Given this list of marker genes Aoc3, F8, Gstp1, Ednrb, Il4, Pik3cg, Tnf, Plscr1, Ptgs2, Nlrp6, Itih4 (NCBI Gene Id 16427), Alox5ap (arachidonate 5-lipoxygenase activating protein), Adora1, Ffar2, Pla2g2d (NCBI Gene Id 18782), Park7 (NCBI Gene Id 57320), Dnase1l3, Tnfsf11, Ugt1a1, C2cd4b, Rhbdd3, Prcp, Icam1, Reg3g, Saa3 (NCBI Gene Id 20210), Eif2ak1, Bdkrb2, Cd163, Tnfrsf11a, Hp, Adam8, Npy5r, Ccl5, Il1b, Ffar3, Reg3b, H2-T23, Saa2, B4galt1, Cnr1, Ighe, Gata3, Serpinf2, Stat3, Pparg, Sigirr, Epo, Fcgr1, Casp6, Lbp, Il20rb, Ins2 (NCBI Gene Id 16334), Btk, Fut7 (fucosyltransferase 7), Nlrp3, Dnase1, Npy, Spn, Hfe, Orm3, Il1rn, Serpina1a (serine (or cysteine) peptidase inhibitor, clade A, member 1A), F12, Cxcr2, Ighg1, Serpina1b, Stat5b, Fcer1a, F2, Il31ra, Adcyap1, Zp3, Acvr1, Orm2, Lipa, Fcgr4, Tac1, Ins1 (NCBI Gene Id 16333), Mylk3, Mrgpra3, Ash1l, Ccr5, Klk1b1, Vwf (Von Willebrand factor), Ccr7, Orm1, Ephb6, Ahsg, Trpv1 (NCBI Gene Id 22366), C2cd4a, Crp, Fcgr2b, Serpina3n, C3, Serpinb9, Tfrc, Ctnnbip1, Cd6, Ptger3 (NCBI Gene Id 19218), Ptges, Reg3a, Ass1, Elane, Fn1, Ighg2b, Selenos, Il1a, Vnn1, Ano6, Scn11a, Il6, Saa1, Nupr1, Fcgr3, Tnfsf4, Fcer1g (NCBI Gene Id 98395), A2m, Tfr2, Ext1, F3, here is a description of the gene set: species: Mus musculus Inflammation which comprises a rapid, short-lived, relatively uniform response to acute injury or antigenic challenge and is characterized by accumulations of fluid, plasma proteins, and granulocytic leukocytes. An acute inflammatory response occurs within a matter of minutes or hours, and either resolves within a few days or becomes a chronic inflammatory response. Mouse Gene Set: GOBP_ACUTE_INFLAMMATORY_RESPONSE